The following is a description of a gene set: Mouse Gene Set: GOBP_THYMOCYTE_APOPTOTIC_PROCESS studied in species Mus musculus Any apoptotic process in a thymocyte, an immature T cell located in the thymus., and this is the list of marker genes: Bbc3, Chek2, Wnt5a, Gli3, Rag1, Efna1, Adam8, Dffa, Bcl10, Casp8, Zc3h8, Bcl2l11, Bmp4, Bax, Vhl, Kifap3, Ptcra, Jak3, Hif1a, Nfkbid, Blm (NCBI Gene Id 12144), Ada, Bak1, Bcl11b, Rorc, Trp53